The following is a description of a gene set: from publication Gao S, Yan L, Wang R, Li J, Yong J, Zhou X, Wei Y, Wu X, Wang X, Fan X, Yan J, Zhi X, Gao Y, Guo H, Jin X, Wang W, Mao Y, Wang F, Wen L, Fu W, Ge H, Qiao J, Tang F (PMID 29802404) species: Homo sapiens Human Gene Set: GAO_ESOPHAGUS_25W_C4_FGFR1HIGH_EPITHELIAL_CELLS, and this is the list of marker genes: GARNL3, CMTM3, NRP1 (NCBI Gene Id 8829), ZKSCAN3, JAM3, PCSK6, LETMD1, TSPAN4, PAMR1, KCTD15, PDGFRB, PIANP, PLXNC1, LUM, LCAT, SH3TC2, PTBP2, ERMARD, CDC23, DLC1, AFAP1L2, TRIM65, SNX21, ZBTB17, ARHGAP30, PHETA1, ADAMTS1, TBC1D8B, ZNF546, FURIN, PI15, IFFO1, ISLR, IKBIP, TNFAIP6, PLEKHG5, CERS3, BMP1, INKA1, SLC37A4, COL16A1, CTSK, GAS1, FAM83C, FKBP7, FZD10-AS1, ELOVL6, FOXF1, TRIM6, CISD3 (NCBI Gene Id 284106), SYT1, ARHGAP10, CRMP1, TMSB15B, DOCK11, ZNF700, ABI3BP, ZNF773, ZDHHC8, CDK5RAP1, KLHL31, ZNF628, THBS2, TGFBR3, CYP1B1, CPZ, FBN1, MED29, METTL25, MMP2, RIC1, TTK, ADAM33, ADGRD1, ZNF354A, ATXN1L (ataxin 1 like), SOCS2, PCOLCE, LHFPL6, CADM4, FBXO44, DDX31, GLT8D2, U2AF2, LINC00330, OGFOD3, SCARA5, LAMA2, METTL17, TARS3, STARD9, PKDCC, FBXO4, ATP9B, HAUS2, DGUOK-AS1, MN1, USP32P2, TADA2B, GPR37, RWDD2A, NOD1, FGFR1, GFRA1, ADGRL3, TRERF1, LINC02256, ADAM22, HSPA1L (NCBI Gene Id 3305), DCHS1, ACKR1, ASPA, GALT, PIGK, ZNF761, HHAT, SLC45A1, NOM1, SNX10, COL17A1, TPGS1, ADAMTS2, MED20, FLRT2, JAM2, PCDH18, EGR2, ABHD8, SLC9A3-AS1, PBK, SLC16A2, WARS2, SHQ1, PRKG2, ZNF512, ETFRF1, COLEC12, HMCN2 (NCBI Gene Id 727754, hemicentin 2), NCBP1, PSMG3-AS1, SLC35A1, POSTN, CHRDL1, USP49 (ubiquitin specific peptidase 49), C17orf100, RTL5, ZNF436, VCAM1, ACP3, ZNF587, TMEM132A, FNDC5, XPNPEP2, GHR, LPAR4, DENND10, VSTM4, TMEM144, SVEP1, P3H3, ZFHX4, HIC1, ZZEF1, ARMH4, SLIT3, ADAMTSL1, KLHL21, ZNF799, POLL, TRIO, ARHGAP42, RARRES2, STAT5B, FECH, ROBO3, AARS1, PI16, ASB2, TROAP, DAGLA, GRK5, ACOT9, APCDD1L-DT, CRKL, MFAP5, SH3PXD2B, NOMO1, FKBP10, CILP, CSAD, KDELR3, PCDH9, GABBR1, COL5A3, ZSCAN22, FRRS1, ADGRB2, FSIP2, SDHAF4, ATP1A1-AS1, DLK1, TENM4, MFAP4, SEH1L, SNHG15, CA2, PDGFRL, AOX1